The following is a description of a gene set: Any process that modulates the frequency, rate or extent of membrane depolarization during a cardiac muscle cell action potential. Mouse Gene Set: GOBP_REGULATION_OF_MEMBRANE_DEPOLARIZATION_DURING_CARDIAC_MUSCLE_CELL_ACTION_POTENTIAL studied in species Mus musculus, and this is the list of marker genes: Cav3, Gja5, Slmap, Ank3, Rangrf